The following is a description of a gene set: from publication Yevshin I, Sharipov R, Kolmykov S, Kondrakhin Y, Kolpakov F (PMID 30445619) Genes containing one or more binding sites for (LMNB2) in their promoter regions (TSS -1000,+100 bp) as identified by GTRD version 20.06 ChIP-seq harmonization. studied in species Homo sapiens Human Gene Set: LMNB2_TARGET_GENES, and this is the list of marker genes: TFAP4, MGRN1, SQSTM1, TMEM179B, DKK1, CLPB, PITX3, FRMD6, ZCCHC4, PDSS2, CCDC124, TPGS2, SLCO3A1, KIAA1328, MIR7155, ELOVL2-AS1, ELOVL2, RAPGEF3, TBC1D4, CBX4, JUP, ZBTB39, H3C9P, RPIA, SRF, RBBP5, LZTS2, PDE4A, MARCHF7 (membrane associated ring-CH-type finger 7), SMARCD2, CORO6, CCDC88B, FKBP7, PRKG1-AS1, TGFB1I1